Given this list of marker genes PLXDC1, MAP2K5, BRCA1, SEC24D, CTAGE1, B3GALNT1, IFI6, TRPC3, RARB, here is a description of the gene set: Genes up-regulated in DU-145 cells (prostate cancer) expressing a dominant negative form of AKT1 upon sham-treatment for 48 h (as a control for the HGF experiments). from publication Xu J, Gao M, Fan S, Meng Q, Goldberg ID, Abounader R, Ressom H, Laterra JJ, Rosen EM (PMID 17099727) The cytokine scatter factor (SF) (hepatocyte growth factor) transduces various biologic actions, including cell motility, invasion, angiogenesis and apoptosis inhibition. The latter is relevant to understanding the role of SF in promoting tumor cell survival in different contexts, for example, detachment from basement membrane, growth in metastatic sites and responses to chemo- and radiotherapy. Previously, we showed that SF protects cells against apoptosis owing to DNA damage, by a mechanism involving phosphoinositol-3-kinase/c-Akt signaling. Here, we used DNA microarray assays to identify c-Akt-regulated genes that might contribute to cell protection. DU-145 human prostate cancer cells were transfected+/-a dominant-negative mutant Akt, treated+/-SF and analysed for gene expression using Affymetrix arrays. These studies identified SF-regulated genes for which induction was c-Akt-dependent vs -independent. Selected microarray findings were confirmed by semiquantitative and quantitative reverse transcription-polymerase chain reaction. We tested the contribution of four SF-inducible/c-Akt-dependent genes (AMPD3, EPHB2, MX1 and WNT4) to protection against adriamycin (a DNA topoisomerase IIalpha inhibitor) using RNA interference. Knockdown of each gene except EPHB2 caused a small but significant reduction in the SF cell protection. The lack of effect of EPHB2 knockdown may be due to the fact that DU-145 cells contain a single-mutant EPHB2 allele. A combination of three small interfering RNAs blocked most of the protection by SF in both DU-145 and T47D cells. These findings identify novel c-Akt-regulated genes, some of which contribute to SF-mediated cytoprotection. studied in species Homo sapiens Human Gene Set: XU_AKT1_TARGETS_48HR